The following is a description of a gene set: studied in species Homo sapiens from publication Chen Y, Wang X (PMID 31504780) Human Gene Set: MIR2117 Genes predicted to be targets of miRBase v22 microRNA hsa-miR-2117 in miRDB v6.0 with MirTarget v4 prediction scores > 80 (high confidence targets)., and this is the list of marker genes: BTF3L4, USP32, TUBGCP4, PIK3R4, ZNF268, TRAPPC6B, GPRASP1, TMEM234, PLPP5, PGM5, KCNN3, STK38L, RPS6KC1, ESYT2, TTPA, BCL2L13, TMEM248, BCAT1, ZNF37A, ZSWIM6, RUNX1T1, SMAD9, THSD7A, PURB, TBX18, DLG3, CSRP3, ARID2, IL1RAP, ATOSB, MSANTD3, NOLC1, CPSF2, HKDC1, PTGER4, PHLPP1, LRRTM3, UGT2A3, SNRPB, SIGLEC6, CYB5R4, BNIP2, OR51E1, LARP4, RASSF3, KLHL18, DNAJC14, RABL3, AGFG1, FRRS1, ASB4, ENPP1, RGS7BP, CDC42SE2, OSBPL11, EIF2S1, ZNF711, UTY, PMM1, RPRD2, EVI2A, CR1, ZBTB20, BMP3, CFAP91, QNG1, PAG1, TMEM260, F2RL2, RAB40C, JARID2, RBM12, RO60, BORCS7, PSIP1, GAD2, KAZN, TRIM71, MRPL9, CAMK1D, CNDP2, IL22RA2, STX6, DNAJC22, ZNF322, PLCD4, DAB2IP, CD93, ARG2, PAK5, TAF4, NUDCD1, POLR3B, PAICS, ARHGEF18, CPVL, COX11, PIAS1, ANXA3, ALDH9A1, NOG, ATP2A2, JCHAIN, CCDC186 (coiled-coil domain containing 186), ZNF385D, C9, NFASC, SDCBP2, HOXC5, FAM114A1, VRK2, TRIM33, TNRC6B, KIT, EHD2, OPRM1, LIMA1, PELI2, AP4S1, TM2D1, TFAP2E, YTHDF2, TMEM132E-DT, NTNG2, ACP3, NPFFR2